The following is a description of a gene set: Mediastinal lymphadenopathy studied in species Homo sapiens Human Gene Set: HP_MEDIASTINAL_LYMPHADENOPATHY Swelling of lymph nodes within the mediastinum, the central compartment of the thoracic cavities that contains the heart and the great vessels, the esophagus, and trachea and other structures including lymph nodes., and this is the list of marker genes: APOE, P4HA2, CYBA, BTNL2, MALT1, CYBC1, RASGRP1, MAGT1 (magnesium transporter 1), PTPN22, IRF4, NCF1, HLA-DPB1, BCL10, HLA-B, EWSR1 (EWS RNA binding protein 1), WT1, NCF2, CYBB, BCL6, BCL2, PRKCD, AGR2, HLA-DRB1, IRF1 (interferon regulatory factor 1), BIRC3, FOXP1, TERT, EIF2AK4, PIK3CG, NCF4